The following is a description of a gene set: studied in species Homo sapiens The chemical reactions and pathways resulting in the formation of glycerophospholipids, any derivative of glycerophosphate that contains at least one O-acyl, O-alkyl, or O-alkenyl group attached to the glycerol residue. Human Gene Set: GOBP_GLYCEROPHOSPHOLIPID_BIOSYNTHETIC_PROCESS, and this is the list of marker genes: SLC44A3, PITPNM1, PTDSS2, APOA2, CWH43, SYNJ1 (NCBI Gene Id 8867), HTR2C, DGKD, PIK3C3, PGAP1, LIPH, MFSD2A, LIPI, IP6K2, IMPA2, PLA2G4A, SH3GLB1, PIP4K2C, LPCAT4, MTM1, ITPKA, PNPLA3, DGKE, DGKI (NCBI Gene Id 9162), INPP4B, PITPNM2, CRLS1, PGAP4, PIGG, HTR2A, GPAM, PIGS, MTMR14, MTMR1, ATM, LPIN1, APOA1, PTDSS1, CEPT1, AGPAT4, PIK3CB, PIGK, MTMR7, DPM2, ETNK2, PI4KA, INPP5K, INPPL1, PIK3CG, PIGC, ACP6, PI4KB, SMG1, SH3YL1, PIGA, ITPKC, TTC7A, BECN1, CAPN2, PIK3R4, PIPSL, PIP5K1B, PIGT, DGKK, HYCC1, RAB38, AJUBA, IMPA1, EFR3B, PIGX, PIK3C2A, CDS1, PI4K2A, INPP5F, GPAA1, GPAT4, PCYT2, PIGW, PIKFYVE, SLC44A2, CHKB, LPCAT1, PIP4K2B, OCRL, PIGF, PLD2, DGKH, DGKA, PGS1, INPP5D, PIP5K1C, PLD1, LPCAT2, ABHD4, NR1H4, AGPAT3, CLN3, BPNT1, IP6K1, GPAT3 (NCBI Gene Id 84803), PI4KAP2, TAMM41, ACSL3, PCYT1A, PGAP3, MBOAT7, AGPAT5, DPM1, INPP5E (NCBI Gene Id 56623), PDGFB, MTMR2, PIP5K1A, MTMR4, CHAT, TMEM150A, PCYT1B, FABP5, ABHD5, SLC44A4, ITPKB, PISD, LCLAT1, DPM3, PIGP, PGAP2, PIGV, INPP5J, PIP5KL1, INPP1, PLSCR1, PI4K2B, PIGQ, PTEN, PIK3C2G, IP6K3, MPPE1, PTPRQ, FAR1, PDGFA, HDHD5, PIGB, LCAT, EFR3A, AGPAT1, VAC14, PIK3C2B, HYCC2, PEMT, ABHD3, ATG14, CDS2, SLC44A5 (solute carrier family 44 member 5), FIG4, PIGO, GNPAT, PLCG2, CDIPT, PIGZ, PIK3R3, SLC30A5, PIK3CD, GPAT2, BPNT2 (3'(2'), 5'-bisphosphate nucleotidase 2), SLC44A1, DGKG, CHKA, PIGU, PIGH, PIK3CA, FABP3, UVRAG, PIK3R1, AGPAT2, SACM1L, TPTE2, PLA2G4C, PIGM, PIP4K2A, INPP4A, PIGY (phosphatidylinositol glycan anchor biosynthesis class Y), BMX, TTC7B, DGKQ, PIGL, CHPT1, SYNJ2, MTMR6, ETNK1, PTPMT1, HTR2B, LPCAT3, DGKZ, DGKB, SELENOI, ALOX15, ABHD8, PITPNM3, MTMR3, PIGN